The following is a description of a gene set: from publication Chen Y, Wang X (PMID 31504780) studied in species Homo sapiens Human Gene Set: MIR6763_5P Genes predicted to be targets of miRBase v22 microRNA hsa-miR-6763-5p in miRDB v6.0 with MirTarget v4 prediction scores > 80 (high confidence targets)., and this is the list of marker genes: SLC25A37, GRIK3, TMTC3, CPSF7, SMARCC2, TLN1, PCDHB4, ENO2 (enolase 2), FA2H, PRKAR1B, NCDN, SLC16A2, FBXO41 (F-box protein 41), GPD1, CIB2, FKBP10, BRME1, RAB7A, ZNF280B, AQP2, ELK1, ELAVL3, EEA1, PDZD7, TTC9, SNCB, PA2G4, OAF (out at first homolog), ADCY9, GATAD2B, CSNK1A1, SELENOP, VAT1 (vesicle amine transport 1), CDR2L, C1orf21, NAALADL2, SCRT2, TRAM1, ZNF618, NECTIN1, HAPLN4, SEMA5A, TMT1B, IRAG2, OPN5, VCAN, NACC1, CHD3, BARHL1, SPATA31D3, DLK1, FREM1, SCN4A, COP1, CCDC97 (NCBI Gene Id 90324), STMND1, IFNLR1, SNX33, NOVA2, PLAC8L1 (PLAC8 like 1), WNK3 (NCBI Gene Id 65267), FGFR1, IRGQ, CD1E, MYPOP, CDCA5, PPP4R3B, LIMD2, NBL1, BCAM, THY1 (NCBI Gene Id 94105), RD3, AGGF1, HECTD3, CHAD, ATP2B4, SPINDOC, IGFBP5, NHERF1, STIM1, CTIF, CPA5, APOA5, PPP4C, RBM14, ZYG11B, TAF15, PLEKHS1, NEUROD2, HMGCS1, ISLR, RBM38, NSG2, SVIL, SYNGAP1, CSNK1A1L, SPOCK2, ETNK1, POU2F2, KIAA0825, PRX, CAVIN1, IFI6, NOVA1, SEZ6L2, EGLN2, PRKACA, COL5A3, RIMS3